Given this list of marker genes Cyp2r1, Cyp27b1, Ube2i, Cyp24a1, Sumo2, Vdr, Pias4, Gc, here is a description of the gene set: Vitamin D (calciferol) metabolism Mouse Gene Set: REACTOME_VITAMIN_D_CALCIFEROL_METABOLISM species: Mus musculus